Given this list of marker genes MT-ND4, PMM2, MT-TS2, MT-ND6, MT-TL1, WFS1, PRNP, MT-TW, HTRA1, STIM1, MT-CO1, MT-ND5, DPAGT1, NDUFA8, MT-CO3, MT-TQ, MT-TH, LRPPRC, AMACR, LIG3, MT-TK, MT-ND1, DPM3, RFT1, MT-TC, TTR, MT-CYB, MT-TV, MT-TF, MT-CO2, CMPK2, here is a description of the gene set: Stroke-like episode studied in species Homo sapiens Human Gene Set: HP_STROKE_LIKE_EPISODE No consensus exists on what a stroke-like episode is, but these episodes can be functionally defined as a new neurological deficit, occurring with or without the context of seizures, which last longer than 24 hours.